Given this list of marker genes PIGF, RTN4RL2, VNN1, CEACAM7, NRN1, NTNG1, PLAUR, PSCA, NTNG2, ALPL, PRSS21, BST1, XPNPEP2, PIGL, ALPG (NCBI Gene Id 251), PIGT, PIGB, LYPD8, DPM3, NTM, LY6H (lymphocyte antigen 6 family member H), RECK, PLET1, ALPI, PIGS, LY6D, CEACAM5, PIGX, DPM2, OPCML, TECTA, ART4, MDGA2, PIGM, LYPD3 (LY6/PLAUR domain containing 3), PIGK, PIGW, THY1, PIGZ, MDGA1 (MAM domain containing glycosylphosphatidylinositol anchor 1), LYPD5, OTOA, TEX101, GP2, VNN2, MELTF, DPM1, CNTN3, PIGG, PRND, LY6G6D, LY6G6C, FOLR2, SPACA4, FCGR3B, LY6E, IZUMO1R, CPM, PIGC, PIGU, PIGV, RAET1L, GPLD1, LYPD4, NRN1L, NEGR1, GPIHBP1, PIGO, PGAP1, ART3, PRSS41 (serine protease 41), LYPD6B, ULBP2, PIGQ, SPRN, TECTB, LYPD1 (LY6/PLAUR domain containing 1), MSLN, GPAA1, CNTN4, PIGN, PIGH, PIGA, RAET1G, CD52, LY6K, CNTN5, LSAMP, CD109, PIGY, LYPD2, PIGP, RTN4RL1, here is a description of the gene set: Human Gene Set: REACTOME_POST_TRANSLATIONAL_MODIFICATION_SYNTHESIS_OF_GPI_ANCHORED_PROTEINS studied in species Homo sapiens Post-translational modification: synthesis of GPI-anchored proteins